Given this list of marker genes TNFRSF11A, TCIRG1, CA2, ANKH, OSTM1, KARS1, FERMT3, PTDSS1, LRP5, GJA1, TNFSF11, MITF, AMER1, CLCN7, SNX10, PLEKHM1, DHCR24, CSF1R, SLC4A2, here is a description of the gene set: studied in species Homo sapiens Osteopetrosis Abnormally increased formation of dense trabecular bone tissue. Despite the increased density of bone tissue, osteopetrotic bones tend to be more fracture-prone than normal. Human Gene Set: HP_OSTEOPETROSIS